The following is a description of a gene set: Cluster 1: genes up-regulated in lung tissue samples from mice with oncogenic form of KRAS and inactivated PTEN. studied in species Mus musculus Mouse Gene Set: IWANAGA_CARCINOGENESIS_BY_KRAS_PTEN_UP from publication Iwanaga K, Yang Y, Raso MG, Ma L, Hanna AE, Thilaganathan N, Moghaddam S, Evans CM, Li H, Cai WW, Sato M, Minna JD, Wu H, Creighton CJ, Demayo FJ, Wistuba II, Kurie JM (PMID 18281487) Phosphatase and tensin homologue deleted from chromosome 10 (Pten) is expressed aberrantly in non-small cell lung cancer cells, but the role of Pten in lung neoplasia has not been fully elucidated. In this study, we used a genetic approach to inactivate Pten in the bronchial epithelium of mice. Although, by itself, Pten inactivation had no discernible effect on bronchial epithelial histology, it accelerated lung tumorigenesis initiated by oncogenic K-ras, causing more rapid lethality than that induced by oncogenic K-ras alone (8 weeks versus 24 weeks of median duration of survival, respectively). Lung tumors arose in K-ras mutant, Pten-deficient mice that rapidly obstructed bronchial lumina and replaced alveolar spaces. Relative to K-ras mutant tumors, the K-ras mutant, Pten-deficient tumors exhibited more advanced histologic severity and more prominent inflammation and vascularity. Thus, Pten inactivation cooperated with oncogenic K-ras in promoting lung tumorigenesis., and this is the list of marker genes: Fancl, Ramp1, B3galnt2, Bicdl1, 4933438B17Rik, Cdc23, Gm15417, Chac2, Dpys, Fer, Ggnbp1 (NCBI Gene Id 75393), Rnf20, Calhm5, Ints2, Rragd (Ras-related GTP binding D), Odc1, 2900026A02Rik, Isl1, Arl8a, Krtdap, Col5a1, Ntf5, Tmem177, Akap10, Rbm18, Oga, Fhip1b (FHF complex subunit HOOK interacting protein 1B), Senp2, Mif, Ankrd55, 4933433N18Rik, Hspa1b, Nme8, Efcab12, Gmeb1, Cr1l, 1700128F08Rik, Uox, Golm1, 1700034H15Rik, Chl1 (cell adhesion molecule L1-like), Kcnk6, 4930481B07Rik, Tcl1b4, Gm266, Gprc5c, Lmx1a, Phf10, Pdgfc, Elavl3, Serpina3k, Mynn, Bhlhe40, Tdrp, Lamp2, Bcap29 (B cell receptor associated protein 29), Eif4ebp2, Nfatc2, Il36rn, Mageb16, Rprd2, Ndufs6, Atp6v0a1, Zfp827, Siglec1, Sprr2a1, Pgk1, Nol11, Frem2, Smpdl3b, Gsta4, Gabrp, Zfp942, Mapk8, Tuba4a, F3, Cetn4, Bche, Car10, Gm11149, 8430436N08Rik, Adamdec1, Gabra1, Inava, Ly6d, Gtf3c4 (general transcription factor IIIC, polypeptide 4), Mettl26, Rab7, Map6, Gid4, Acot3, Zfp414, Tex13b, Myb, Ccr1, Ercc6l, Higd1a, Igbp1, Litaf, Recql, Arg1, Rgs5, Egln3, Cd14, Ncapd3, Hes2, Grin1, Lmnb1, Ipo13, Pkib (protein kinase inhibitor beta, cAMP dependent, testis specific), Trp63, Tbca, Serpine1, Zc3h14, Nt5c2, Gemin5, Lamb3, Rab39, Enpep, Rsl1d1, Arih1, Acap2, Hint3, Adam19, Supt20, Cldn2, Hgf, Nefm, Slc17a9, Serpinf1, Mfsd4a, Gla, Kif2a, Hmox1, Prg4, Sftpa1 (surfactant associated protein A1), Cp, Dtnb, Rnf128, Tvp23a, Ldhd, Cylc2, D17H6S56E-5, Appl1, Slc5a1, Zfp691, Oprl1, Axin2, 5033403F01Rik, Ercc2, Foxj1, Mpzl2, Ldb1, Calb1, 4930408K08Rik, Gm22009, Kng1, Smgc, Gsdma2 (gasdermin A2, NCBI Gene Id 78322), Ppic, Gpr149, Bmerb1, Akirin2, Dmbt1, Cdhr1, Bnip2, Zfp418, Xpo4, Tmem33, Rpgr, Ifna4, Plch2, Dcaf12, Pgm3, Zmynd11, Zfp955a, Kbtbd12, Atp6v1c1, Nudt6, Ret, B9d1os, 4933404G15Rik, Mib1, Top1, Akap8, Morc1 (microrchidia 1), Ccl9, Rbm26, Rbm46, Hspa2, Polg, Wwp2, Mia, Trim71, Hes3, Pgap1, 4933432K03Rik, Cul4b, Tmem107, C3ar1, Bace2, Wnk1, Mis18a, Tcf7l2, Adamts10, Copg1, Uba2, Bzw1, Nucb2, Tcaf2, Ctsb